Given this list of marker genes ADRA2A, RNF41, OXSR1, PPT1 (palmitoyl-protein thioesterase 1), PIGK, ALPL, SIL1, SORT1 (sortilin 1, NCBI Gene Id 6272), FTL, HECTD1, PPP1CC, AOC1 (amine oxidase copper containing 1), HNRNPA3, TC2N, KCNJ12, FXR1, POLR1D, GABRA2, CST6, DTD2, RABGAP1L, MICOS10, CCDC59, SLC6A12 (solute carrier family 6 member 12), SMARCD3, NCMAP, ADAM19, HNRNPK, DHX38, MPND, FGA, RNF187, ARF6, NDST1, LHCGR, HOOK2, CXCL6, MPG, ARHGEF10L, SSR4, USP43, HNRNPU, PRKD1 (NCBI Gene Id 5587), GJD2 (NCBI Gene Id 57369), ZFAND5, EIF3A, PM20D1, PCDH10, CLEC4G, GOLGA3, C2orf42, CEP290, CFL1, DMD, GLIS1, RIPK4, MTHFR, CORO2B, IL12RB1, EAF2 (NCBI Gene Id 55840), GZMA, PNCK, VNN2, RPL3L, BICD2, NEFH, UBXN4, MFAP5, FOXD2, CPSF3, PDCD6IP, AMBP, ATP2C2, SLFN12, SFRP5, CWC27, ADIPOQ, DOC2B, ZNF768, CAMKK1, EFL1, TOMM70, SYNE4, HIC2, UPK2, RPL39, NGDN, RUVBL2, VIM, CDK12, RAP1A, GGT5, ITIH1, ARCN1, NKAIN4, ZNF287, WNK1, ASTN2, OBI1, RDX, SBNO1, LSM1, SRPK3, MATN4, USP8, SH2B2, TNFAIP6, SEC61A1, SNN, KRT36, ARHGAP8, ACVR2B, DDX54, LRRC49, FSCN3, SMC5, EIF4H, CHRNA7, TMCC2, MAGED2, UQCRQ, IL34, DEGS1, DNMBP (NCBI Gene Id 23268), GDF5, UQCR11, KLK11, NOL7, LOXL2, PDZRN3, MDM2, CDON, ANGPT1, PTK6, DCAF15, PLEKHA6, SNHG11, TOX4, MECR, FEM1B, ATXN2, ADAMTS8, NUDCD2, SERBP1 (SERPINE1 mRNA binding protein 1), DCAF4, PPIB, TPM3 (tropomyosin 3), RASSF8, RBM39, CYRIB, CAMKK2, FGF21, OCIAD1, TLX2, EIF4G2, DNAJC2, WARS1 (NCBI Gene Id 7453), RERG, CANX, SPOUT1, RRAS2, PRKN, FOXO4, AARD, ALCAM, MCFD2, ALX3, CCNA1, ACTA1, RPN2, FKTN, PROK2, NTNG1, SEC61B, HK2, ECRG4, ATP8A2, DDX4, BCL2L15, AGPAT5, PC, GJA3, HNRNPA2B1 (NCBI Gene Id 3181), SPOCK3, CDH8, HDLBP, RBMS2, PSMC4, UBR2, POLR3K, ATP2B2, PRG2, DUS1L, NDUFB6, NFE2L1, CLDN19, SLC8A3 (solute carrier family 8 member A3), DIAPH2 (NCBI Gene Id 7989), PSMF1, ASB16, here is a description of the gene set: Genes down-regulated in KLRG1 low CD8 T effector cells during infection: ID2 knockout versus BCL2L11 knockout. Human Gene Set: GSE41978_ID2_KO_VS_BIM_KO_KLRG1_LOW_EFFECTOR_CD8_TCELL_DN species: Homo sapiens CD8+ T cells play a crucial role in the clearance of intracellular pathogens through the generation of cytotoxic effector cells that eliminate infected cells and long-lived memory cells that provide enhanced protection against reinfection. We have previously shown that the inhibitor of E protein transcription factors, Id2, is necessary for accumulation of effector and memory CD8+ T cells during infection. Here we show that CD8+ T cells lacking Id2 did not generate a robust terminally-differentiated KLRG1hi effector population, but displayed a cell-surface phenotype and cytokine profile consistent with memory precursors, raising the question as to whether loss of Id2 impairs the differentiation and/or survival of effector-memory cells. We found that deletion of Bim rescued Id2-deficient CD8+ cell survival during infection. However, the dramatic reduction in KLRG1hi cells caused by loss of Id2 remained in the absence of Bim, such that Id2/Bim double-deficient cells form an exclusively KLRG1loCD127hi memory precursor population. Thus we describe a role for Id2 in both the survival and differentation of normal CD8+ effector and memory populations. from publication Knell J, Best JA, Lind NA, Yang E, D'Cruz LM, Goldrath AW (PMID 23325888)